Given this list of marker genes TRIP6, RASAL2, SERF2, RAP1GAP, PCM1, COL6A1, DENND1B, CH25H, POLD1, EHD4, CD209, HMOX2, C1orf54, CHEK2, SESN1, DHRS11, MCM6, AP3M2, NET1, DNPH1, CBR3, DCTPP1, PI4K2A, MCUR1, ISYNA1, HMGN1, RASGRP3, DNAJB4, SDC2, EPAS1 (endothelial PAS domain protein 1), ADORA3, ALDH5A1, ZCCHC2, SLC37A4 (solute carrier family 37 member 4), S100B, TOMM70, MYO1E, PCBD1 (pterin-4 alpha-carbinolamine dehydratase 1), DHCR24, DAB2, NENF, PTGS1, HACD3, EPRS1, EFCAB11, MAF, APMAP, EPB41L2, MIPEP, PALS1, MDH1, SLCO2B1, ILVBL, STARD7, CD1A, SWAP70, PSEN2, STAC, ACOT13, DNMT1, MRC2, CD84, ADCY3, GINS1, A2M, C1QB (complement C1q B chain), MKNK1, ABR, PCCB, SPTAN1, DOLK, LMNA, AFG3L2, PEA15, ECM1, DONSON, GAS6, CTNNAL1, PXDC1, NIT2, CACYBP, PFKP, FABP4, C1QA, TSPYL5, DOCK3 (dedicator of cytokinesis 3), KIFAP3, MICALL2, CCNE1, GPX3, AIFM1, GOT1, MGAT4A, MFSD12, ACE, CCL22, TNS1, ACO2, AARS1, ID3, MTX2, TIGAR, DAGLA, ZNF804A, GLRX2, CTSC, CCL13, APOO, ZNF274, ALDH3A2, SLC17A5, FILIP1L, HSPA4, LONP1, RNF170, ACOT7, P2RY11, ATP1B1, QPRT, FLVCR2, HMG20B, PHTF2, CTSB, SLC27A3, CD81, RASAL1, NAGPA, LARP4, SLC48A1, JAG1, ANXA11, TRPV2, NDUFA1, CALR, PPIC (peptidylprolyl isomerase C), ZWINT, ZNF134, PPA2, KCTD7, MAOA, NT5DC2, BRCA2, SLAMF8, GABARAPL1, EBP, SEPTIN11, EVL, ADCK2 (NCBI Gene Id 90956), FPR3, MYL9 (NCBI Gene Id 10398), TRIM32, UNG, FABP3, MAP1S, SPINT2, TAX1BP3, LPP, ME1, SLC47A1, COLEC12, ACY1, GSTM4, RRP1B, ZFYVE21, ABHD6, ACP5, DIPK1A, RAMP1, PNN, HSD11B1, GSN, FABP5, CD1E, CHKA, DOCK1, AVPI1, AKIP1, NDUFV2, HOMER2, CD1B, BLNK (NCBI Gene Id 29760), FAM162A, PLAU, SPINT1, HSPB1, PON2, SLC16A1, FCER2, NCAPH, CCL17, PEBP1, RSU1, POLR3K, HOMER1, BCAR3, SLC6A8, MLYCD, TWSG1, SEPHS2, TOX, here is a description of the gene set: Immune cell-specific expression is one indication of the importance of a gene's role in the immune response. In order to identify such patterns, we set out to broadly profile gene expression in a variety of immune cells. studied in species Homo sapiens Human Gene Set: GSE22886_DC_VS_MONOCYTE_UP Genes up-regulated in comparison of dendritic cells (DC) versus monocytes. from publication Abbas AR, Baldwin D, Ma Y, Ouyang W, Gurney A, Martin F, Fong S, van Lookeren Campagne M, Godowski P, Williams PM, Chan AC, Clark HF (PMID 15789058)